The following is a description of a gene set: species: Mus musculus Mouse Gene Set: MIR_3112_3P from publication Chen Y, Wang X (PMID 31504780) Genes predicted to be targets of miRBase v22 microRNA mmu_miR_3112_3p in miRDB v6.0 with MirTarget v4 prediction scores > 80 (high confidence targets)., and this is the list of marker genes: Pabpc6, Nedd9, Cacna1b, Rgn, Phip, Fndc3c1, Peli1, Hoxa5, Wasf2, Zfp148, Exoc2, Zfp384, Scfd2, Zeb2, Csn3, Lcorl, Cadm2, Nfia, Agl, Trpc6, Plekha3, Ppp2r3c, Rnf149, Pak5, Repin1, Chrna7, Polr2c, Cstf3, Clip1, Shroom2, Jmjd4, Hspa1b, Arpp21, Rsl1d1, Scn8a, Or13c7, Fbxl17 (F-box and leucine-rich repeat protein 17), Ppp1cb, Rbpj, Tada1, Lrp2bp, Scai, Sinhcaf, Cep295, Epc1, Rbm47, Ccdc15, Erc1, Nxph2, Lix1, Ino80d, Cpne3, Tet1, Eml5, Ankrd61, Rps6ka1, Atp4b, Mdga2, Rab33a